Given this list of marker genes Il33, Havcr2, Ascl2, Jak3, Il1rl1, Tnfsf4, Il4ra, here is a description of the gene set: studied in species Mus musculus Any process that stops, prevents, or reduces the frequency, rate, or extent of a T-helper 1 type immune response. Mouse Gene Set: GOBP_NEGATIVE_REGULATION_OF_T_HELPER_1_TYPE_IMMUNE_RESPONSE